The following is a description of a gene set: The side (leaflet) of the mitochondrial inner membrane that faces the matrix. Mouse Gene Set: GOCC_MATRIX_SIDE_OF_MITOCHONDRIAL_INNER_MEMBRANE studied in species Mus musculus, and this is the list of marker genes: Dnajc19, Ambp (alpha 1 microglobulin/bikunin precursor), Bdh1, Noa1, Ndufaf5, Coa8, Dmd